Given this list of marker genes Mus81, Rfc3, Dna2, Ccna1, H4c1, Firrm, Xrcc3, Rad51c, Pold2, H4c14, Rad51ap1, Rnf168, Slx1b, H4c6, H4c12, Trp53bp1, Polk, Ercc4, Brca2, H4c2, H2bc3, H2bc15, Wrn, H2bc12, Pias4, Ppp4r2, Rpa1, H4c4, H2bc8, H4c8, H2bc27, Babam1, Pole2, Pold1, Palb2, Fignl1, Brca1, Bard1, Polq, H2ax, Xrcc1 (X-ray repair complementing defective repair in Chinese hamster cells 1), H2bc9, Pcna, Polh, Mre11a, H4c17, H2bc22, Top3a, Ube2n (NCBI Gene Id 93765), Gen1, Lig1, H2bc7, Rnf4, H4c18, H4c11, Brcc3, Rad52, Pole, H2bc1, Rps27a (NCBI Gene Id 78294), Hus1, Ubb, Kat5, H2bc13, Ppp4c, Rbbp8, H4c9, Pold4, Ercc1 (excision repair cross-complementing rodent repair deficiency, complementation group 1), Mdc1, Nbn, H4c3, Blm (NCBI Gene Id 12144), Slx4, Rfc1, Rad51b, Rad1, Rad9a, H2bc11, here is a description of the gene set: This event has been computationally inferred from an event that has been demonstrated in another species.<p>The inference is based on the homology mapping from PANTHER. Briefly, reactions for which all involved PhysicalEntities (in input, output and catalyst) have a mapped orthologue/paralogue (for complexes at least 75% of components must have a mapping) are inferred to the other species. part of: DNA Double-Strand Break Repair Reactome Pathway: Homology Directed Repair species: Mus musculus electronically inferred by orthology from the curated human pathway